Given this list of marker genes MTMR11, RHOBTB1, PMP22, TRIM31, CYP4F12, ICAM2, RAB31, PLA2R1, TCF21, COL6A2, CAVIN3 (NCBI Gene Id 8990), GTF3A, RNF19B, DDR2, BNC2, PEG10, FKBP10, MYL9, PHYHIP, ADAM23, MT1G, ABI3BP, STX11, CIB1, HOPX, CCDC69, MSC (NCBI Gene Id 9242), BCL2L14, NAB1, MAP3K5, SGCE, CD164, ADRA1A, COL5A2, IRF2, LRP1, BCAS1, IER5, INTS11, EFEMP2, LYZ, TGFB1I1, CTSE, GRIN2D, EFEMP1, MYB, PAPSS2, CEP170B (NCBI Gene Id 283638), MARCKSL1, MISP, NRP2, NPDC1, COL5A1, LIMA1, HPGD, RRAS, ECM1, EPHA2, GPRC5A, ZFP36L1, QPCT, DDIT4, LSP1, ALOX5, ATOSB, PAQR3, FABP1, ETNPPL, AEBP1, LCK, ACSL5, SPAG4 (sperm associated antigen 4), SV2A, GNA15, UNC5C, AQP9, BGN, SEC24D, SORD, BNIP3L, SEMA7A, EMP1, LY75, MXRA8 (NCBI Gene Id 84308), TMEM47, FBXW7, TRPV2, SGCA, CDA, FBN1, PTK2B, CREB3L1, RCN3, VCAM1, TSPAN1, ROR2, ELK3, KMT5AP1, VASP, THBS2, ADGRA2 (NCBI Gene Id 84863), SULT1E1, CCZ1, KCNN4 (potassium calcium-activated channel subfamily N member 4), CDC42EP2, MUC1 (mucin 1, cell surface associated), IFI27, MUC5B, PTGS2, CLEC2B, DEPP1, TSPAN13, BMP1 (NCBI Gene Id 649), TMC7, GAS1, SEMA3A, CDYL, DKK1, EMP3, LRRC32, VDR, ITGB6, ARHGAP26, HSPG2, MT2A, TRAM2, TM4SF5, ECE1, CD82, EFHD2, ANG, MMP28, SPINK1, ZBTB48 (NCBI Gene Id 3104), LTBP4, FUT8, RAPGEFL1, NCOR2, RIN2, XPNPEP1, H1-3 (H1.3 linker histone, cluster member), CRYBG1, IFNGR2, RCN1, IFNGR1, SLC2A5, RARRES1, INF2, KSR1, ATP2A3, MMP14, HK2, INPP1, NET1, TPK1, MAPK3, PEX14, ETV7, IGF2BP2, CYP1B1, NOVA2, IGF2BP3, CNN2, NUCB2, MOXD1, TPM2, PDLIM3, PTGIS, PCK2, PALLD, KCNMB4, CHPF, PRSS3, PDZRN3, PLAC8, RPP25, COL3A1, DVL1, AGR2, MYD88, ADAM8, PTPRR, CTBS, ATP8B2, FAP, MANSC1, DKK3, CITED2, ZFPM2 (zinc finger protein, FOG family member 2), PLTP, PELI2, CDH17, TIMP1, NDRG1, TWF2, FXYD3, BDH1, SMPDL3B, RBMS1, GEM (NCBI Gene Id 2669), EMILIN1, IL2RG, VEGFC, ARHGAP10, TRAF3IP2, SYK, KLF5, ANGPTL2, MGAM2, SEPTIN11, TSEN34, MFAP2, RHOF, ACTA2, PRKCD, FER1L4, MGAT3, PROCR (NCBI Gene Id 10544), VILL, SNCA, BACH1, CLIC3, MTHFD2, CYP4F3, ALDH2, NIBAN1, RARB, TOX3, GSTP1, SULT1B1, TMBIM1, KCNE4, SLC44A4, MX2, RPS6KA1, SDF4, ARHGAP17, MLXIP (NCBI Gene Id 728551), SYTL2, PRSS12, CNTNAP1, SERPINB1, PIK3C2G, ARL4A, TPSAB1, HECA, FMO2, CCL18, AHR, IRAK3, RASL11B, MALL, GATA6, AOC3, PLEKHM2, TAGLN, DGKA, BST1, ARRB1, CACNA2D1, FUT2, SELENOW (NCBI Gene Id 6415), CR1, PDLIM4, PACRG, ADAMTS2, SEPTIN9, MAPRE2, EFNB1, CCN2 (cellular communication network factor 2), SIPA1 (NCBI Gene Id 6494), MT1X, TMC6, ZDHHC3, here is a description of the gene set: from publication Villanueva A, Hoshida Y, Battiston C, Tovar V, Sia D, Alsinet C, Cornella H, Liberzon A, Kobayashi M, Kumada H, Thung SN, Bruix J, Newell P, April C, Fan JB, Roayaie S, Mazzaferro V, Schwartz ME, Llovet JM (PMID 21320499) Genes under-expressed in stem cell-like cholangiocellular carcinoma In approximately 70% of patients with hepatocellular carcinoma (HCC) treated by resection or ablation, disease recurs within 5 years. Although gene expression signatures have been associated with outcome, there is no method to predict recurrence based on combined clinical, pathology, and genomic data (from tumor and cirrhotic tissue). We evaluated gene expression signatures associated with outcome in a large cohort of patients with early stage (Barcelona-Clinic Liver Cancer 0/A), single-nodule HCC and heterogeneity of signatures within tumor tissues. Human Gene Set: OISHI_CHOLANGIOMA_STEM_CELL_LIKE_DN studied in species Homo sapiens